The following is a description of a gene set: GABA synthesis, release, reuptake and degradation studied in species Homo sapiens Human Gene Set: REACTOME_GABA_SYNTHESIS_RELEASE_REUPTAKE_AND_DEGRADATION, and this is the list of marker genes: CPLX1, SLC6A12, ABAT, HSPA8, SYT1, SLC6A1, SNAP25, DNAJC5, SLC6A13, RAB3A, VAMP2, STXBP1, SLC6A11, ALDH5A1, RIMS1, STX1A, GAD1, SLC32A1, GAD2